Given this list of marker genes Rad51c, Eme1, Xrcc3, Mus81, Slx1b, Gen1, Eme2, here is a description of the gene set: species: Mus musculus Mouse Gene Set: GOMF_CROSSOVER_JUNCTION_DNA_ENDONUCLEASE_ACTIVITY Catalysis of the endonucleolytic cleavage at a junction such as a reciprocal single-stranded crossover between two homologous DNA duplexes (Holliday junction).